The following is a description of a gene set: studied in species Mus musculus This event has been computationally inferred from an event that has been demonstrated in another species.<p>The inference is based on the homology mapping from PANTHER. Briefly, reactions for which all involved PhysicalEntities (in input, output and catalyst) have a mapped orthologue/paralogue (for complexes at least 75% of components must have a mapping) are inferred to the other species. electronically inferred by orthology from the curated human pathway Reactome Pathway: Antimicrobial peptides part of: Innate Immune System, and this is the list of marker genes: Defa23, Try10, Defa35, Ccr6, Rnase2a, Bpifa2, Ctsg, Defa37, Defa43, Defa41, Bpifb6, Svs3b, Prss3 (serine protease 3), Defa24, Elane, Defb1, Art1, Defa39, Defb28, Slc11a1, Camp, Pglyrp1, Bpifb1, Defb14, Tlr1, Defa3, Defb18, Defa25, Defb25, Leap2, Bpifa1 (NCBI Gene Id 18843), Reg3a, Defa38, Pglyrp3, Defa32, Defa31, Defb3, Reg3d, Defa20, Defb42, Defb19, Defb21, Defa26, Bpi, Defb47 (NCBI Gene Id 654465), Defa21, Bpifb4 (NCBI Gene Id 381399), Pdzd11, Tlr2, Pla2g2a, Pglyrp4, Defa30, Defa42, Reg3b, Chga, Defb36, Defa36, Prss2, Reg3g, Defa28, Eppin, Defa17, Defb43, Prtn3, Defa34, Rnase6, Defb48